The following is a description of a gene set: from publication Abbas AR, Baldwin D, Ma Y, Ouyang W, Gurney A, Martin F, Fong S, van Lookeren Campagne M, Godowski P, Williams PM, Chan AC, Clark HF (PMID 15789058) Immune cell-specific expression is one indication of the importance of a gene's role in the immune response. In order to identify such patterns, we set out to broadly profile gene expression in a variety of immune cells. Human Gene Set: GSE22886_NAIVE_VS_IGG_IGA_MEMORY_BCELL_DN species: Homo sapiens Genes down-regulated in comparison of naive B cells versus memory IgG IgA B cells., and this is the list of marker genes: ITGB1, EIF3A, GBA1LP, RORA, ITGAM, ANXA2, SAMSN1, TMEM14A, CCND2, CD27, DYNLL1, TBX2, NANS, GRAP, ELOVL1, TFEC, NDUFS6, ARPC1B, AIM2, RNH1, CRIP2, GOLPH3, UQCRB, ARHGAP25, PSMB9, DEPDC5, ATP1A1, ACAT1, PVRIG, CAB39, S100A6, WEE1 (WEE1 G2 checkpoint kinase), RAB5IF, ZBTB20, ATP2B4, VIM, TFRC, DGLUCY, SLC7A6, CTSA, RPL27A, ECHDC2, SUB1, ITM2C, UBE2J1, LIME1, TBK1, TUBB4B, SCRN1, CD82 (NCBI Gene Id 8052), SND1 (staphylococcal nuclease and tudor domain containing 1), JPT1, DENND1B, SSPN, EHD1, PMM1, GCLC, FUT7, TESC, ACAA2, UBE2G1, EBI3, MFSD10, GSTK1, KCNN4, RASGRP1, MZT2A, SP140, TUBB, KLF10, GAPDH, PRDX3, CCT5, PLSCR3, HSPA8, SMAGP, MVP, MKKS, JCHAIN, AP3S1, TSFM (Ts translation elongation factor, mitochondrial, NCBI Gene Id 10102), CBR3, APOL3, CRIP1, BHLHE40, PLCG2, DPYSL2, ACTG1, ARPC5L, TRAC, CCNG1, ATP5F1A, BAIAP3, VOPP1, SEC61B, COTL1, PXDC1, TFDP1, BIN1, FBXO2, EEIG1, PLP2, CSGALNACT1, MTHFD1, AGBL5, IFI30, SCNM1, MNDA, KMT5A, NCF4, CDV3, KCTD7, FKBP11, SGPP1, RALGDS, UBE2N, LGALS1, ACP5, COCH, TOX, LPXN, CTSH, TNFRSF17, SYBU, THEMIS2, BLVRB, RARS1, GARS1, CLIC1, CFLAR, IGHA1, RAB31, PYCARD, UQCRH (ubiquinol-cytochrome c reductase hinge protein), FAIM, ITGB7, AIFM1, LMO4, BHLHE41, TPI1, EHD3, CD70, CD58, AHNAK, PTPN2, ISG15, CD99, GRAMD1C, COL4A3, SLC35D2, ANXA2P2 (NCBI Gene Id 304), PPA1, NDUFB3, DOCK10, ORMDL2, TRADD, NQO2, EVI2A, TLE3, ZMIZ1, MYO1F, MARCKS, YWHAH, TOR3A, CAPG, SINHCAF, S100A4, DAAM1, S100A10, HOMER3, XBP1, LDHB, ZBTB38, ENO2, HSPA6, DAP, NIBAN1, PANK2, PAPSS1, CAPN2, CD247, ZFAND6 (zinc finger AN1-type containing 6), CD86, HCP5, TMBIM1, NT5C, TBC1D9, RPLP1, ZBTB32, NDUFB7, DDAH2, PLAAT4, RGS10, PPA2, AMPD2, ANXA5